The following is a description of a gene set: studied in species Mus musculus Mouse Gene Set: GOBP_REGULATION_OF_SYNAPTIC_VESICLE_TRANSPORT Any process that modulates the frequency, rate or extent of synaptic vesicle transport., and this is the list of marker genes: Cnih2 (cornichon family AMPA receptor auxiliary protein 2), Borcs5, Picalm, Lrrk2, Map2